Given this list of marker genes KMT2A, EYA1, WAC, SIX1, POLR3A, SIX5, here is a description of the gene set: An abnormal enlargement of the renal calices, the system of ducts of the kidney that collect urine. species: Homo sapiens Dilatation of renal calices Human Gene Set: HP_DILATATION_OF_RENAL_CALICES